The following is a description of a gene set: Human Gene Set: HP_MUTISM Mutism studied in species Homo sapiens Complete lack of speech or verbal communication in a person despite attempts to engage in conversation. Mutism as a phenomena assumes the individual has previous capacity for speech and in the pediatric population it assumes that the person is past the age of typical language development., and this is the list of marker genes: CSF1R, CHMP2B, ADAMTSL2, FGFR1, VCP, GRIN2A, SLC9A6, TCF4, CHCHD10, GLE1, CKAP2L, ATP1A3, FUS, PSEN1, COL1A1, HCCS, PLEC, HNRNPA2B1, AXIN1, COL1A2, NDUFA6, HTT, PIK3C2A, PRPS1, NDUFB11, AMER1, SMARCA2 (NCBI Gene Id 95083), SQSTM1, NTNG1, GABBR2, HNRNPA1, GRN, ACTG1, COX7B, MECP2, ASAH1, EHMT1, PRDM8, SMC1A, TREM2 (triggering receptor expressed on myeloid cells 2), ADAMTS2, TMEM106B, KRAS, FTL, MAPT, TARDBP, TRANK1, TBK1, ACTB, UBE3C, SLC2A3, SLC19A3, GRIN1, TBP, CDKL5